Given this list of marker genes NRDE2, NCBP2, DHX9, CPSF6, KHDRBS1, here is a description of the gene set: Human Gene Set: GOBP_POSITIVE_REGULATION_OF_RNA_EXPORT_FROM_NUCLEUS Any process that activates or increases the frequency, rate or extent of directed movement of RNA from the nucleus into the cytoplasm. species: Homo sapiens